Given this list of marker genes Ucn3, Htr7, Gper1, Star, Fos, Nr3c1, Pf4, Slc12a3, Card9, Cdkn1a, Stk39, Edn1, Fosb, Hdac8, Asns, Avpr1a (arginine vasopressin receptor 1A), Trh, Nr3c2 (nuclear receptor subfamily 3, group C, member 2), Npas4 (neuronal PAS domain protein 4), Cybb, Scnn1g (NCBI Gene Id 20278), Aanat, Htr1b, Foxo3, Rpl27, Src, Scnn1b (NCBI Gene Id 20277), Sgk1, Agtr1a, Th (NCBI Gene Id 21823), Aifm1, Comt, Crh, Nefl, Inhba (inhibin beta-A), Fosl1, Scnn1a, Hdac6, Maob, Ace, Csn1s1, here is a description of the gene set: species: Mus musculus Mouse Gene Set: GOBP_RESPONSE_TO_MINERALOCORTICOID Any process that results in a change in state or activity of a cell or an organism (in terms of movement, secretion, enzyme production, gene expression, etc.) as a result of a mineralocorticoid stimulus. Mineralocorticoids are hormonal C21 corticosteroids synthesized from cholesterol and characterized by their similarity to aldosterone. Mineralocorticoids act primarily on water and electrolyte balance.